The following is a description of a gene set: Human Gene Set: HP_ACCELERATED_SKELETAL_MATURATION studied in species Homo sapiens An abnormally increased rate of skeletal maturation. Accelerated skeletal maturation can be diagnosed on the basis of an estimation of the bone age from radiographs of specific bones in the human body. Accelerated skeletal maturation, and this is the list of marker genes: EED, CAV1, TRPS1, RNF135, SMARCA2, KCNQ1OT1, ABCC9, CYP11B1, MEN1, SLC10A7, PRKG2, GPC4, SUZ12, GLI3, TSHR, XYLT1, DDOST, BSCL2, GPC3, GPR101, AIP, TET3, DDX6, PPARG (NCBI Gene Id 5468), LHCGR, SLC35D1, PTCH1, FOS (NCBI Gene Id 2353), ARCN1, B4GALT7, CAVIN1, B3GAT3, H1-4, EZH2, LEP, ACAN, EFEMP1, INPPL1, KCNJ8, HSD11B1, PDE4D, GNAS, IGF2, MKRN3, CHST3, NSD1, AGPAT2, MC2R, CANT1, CSGALNACT1, RMRP, GUSB, PTH1R, GPX4, UBE3C, NFIX (NCBI Gene Id 4784), LEPR, PRKAR1A, INSR, ALMS1, SLC26A2, MC4R, KMT2A, KCNQ1, CDKN1C, ASXL2, APC2, TCF20